The following is a description of a gene set: species: Mus musculus Mouse Gene Set: GOBP_REGULATION_OF_POSTSYNAPTIC_MEMBRANE_POTENTIAL Any process that modulates the potential difference across a post-synaptic membrane., and this is the list of marker genes: Gabra3, Mtmr2, Gria1, Trpv1, Rims1, P2rx3, Kcna2, Grin2c, Gabrb2, Dvl1, Gabrg3, Tmem108, Ppp3ca, Ppp1r9a, Chrna7, Ssh1, Met, Fmr1, Wnt7a, Chrnb1, Slc17a7, Celf4, Glra4, Atxn1, Sh3gl1, Dmpk, Grid1, Kcna1, Rgs7bp, Grin2a, Grm1, Glrb, Nlgn4l, Grin2d, Igsf9b, Fgf14, Adrb1, Gabbr1, Grin2b, Kcnk1, Gabrg2, Tmem25, Gria4, Bdnf (brain derived neurotrophic factor), Pten, P2rx7, Stx1a, Chrm1, Chrnb4, Dpp6, Nos1, Cdk5, Tbc1d24, Grik1, P2rx4, Sez6, Oprm1, Chrne, P2rx2, Shank3, Hcrt, S1pr2, Grin1, Glra1, Eif4a3l2, Kctd16, Gabrb3, Grin3a, Begain, Grik2, Chrna3, Cux2, Ghrl, Npy2r, Cntnap2, Cbln1, App, Rab3gap1 (RAB3 GTPase activating protein subunit 1), Unc13b, Zmynd8, Npas4, Slc29a1, Ckap5, Nr3c2, Reln, Npff, Cacnb3, Ano6, Pclo, Eif4a3, Chrna5, Mef2c, Gria3, Gabra6, Slc8a3, Lrrk2, Slc1a7, Mapk8ip2, Dlg4, Chrna1, Prkcz, Nrxn1, Chrnb2, Chrnd, Grip2, Prkar1b, Nlgn2, Chrna4, Hcn1, Igsf11, Ptk2b (NCBI Gene Id 211703), Adcyap1, Gabrd, Chrm5, Gabra1, Dgki, Plk2, Rgs7, Adora2a (NCBI Gene Id 11540), Abat, Neto2, Insyn1, Mecp2, Gabra5, Glra2, Grid2, Ntsr1, Eif4a3l1, Shank1, Neto1, Afdn, Gsk3b, Rgs4, Insyn2a, Ngfr, Kcnd2, Rims2, Chrna2, Nlgn1, Gria2, Adora1, Gabrr2, Cx3cl1, Prkn, Mpp2, Adrb2, Nlgn3, Chrng, Glra3, Kcnt1, Kctd12, Gabra2, P2rx1 (purinergic receptor P2X, ligand-gated ion channel, 1), Dbn1, Stx1b, Chrnb3, Slc8a2, Grik5, Baiap2, Grk2, Snca, Gabrb1, Drd4, P2rx6, Chrna6